Given this list of marker genes GATA6 (GATA binding protein 6), BMP4, GSK3B, IL6, MNX1, GDF11, ONECUT1, ONECUT2, BMP5, BAD, GSK3A, ZNF800, CDK6, PDX1, SOX4, SMO, PAX6, NKX6-2, NEUROD1, RFX6, IER3IP1, DLL1, BAK1, PDPK1, BMP6, BHLHA15, AKT1, NKX2-2, HES1, RFX3, SIDT2, RHEB, WNT5A (NCBI Gene Id 7474), INSM1, CDH2, PAX4, GIPR, NKX6-1 (NK6 homeobox 1), FOXA2, IL6R, SOX9, HNF1B, GIP (gastric inhibitory polypeptide), EIF2AK3, CLOCK, BMAL1, MIR541, here is a description of the gene set: studied in species Homo sapiens Human Gene Set: GOBP_ENDOCRINE_PANCREAS_DEVELOPMENT The process whose specific outcome is the progression of the endocrine pancreas over time, from its formation to the mature structure. The endocrine pancreas is made up of islet cells that produce insulin, glucagon and somatostatin.